The following is a description of a gene set: Any process that activates or increases the frequency, rate or extent of the process involved in the formation, arrangement of constituent parts, or disassembly of cell projections. species: Homo sapiens Human Gene Set: GOBP_POSITIVE_REGULATION_OF_CELL_PROJECTION_ORGANIZATION, and this is the list of marker genes: IL1RAPL1, SCN1B, ZMYND10, CORO1B, EHD1, LYN, CRABP2, WASHC5, DVL1, WNT3A, CYFIP1, DLG4, PLEKHM1, RAB11FIP3, DISC1 (NCBI Gene Id 80138), RP1, WRAP73, PROM2, KCTD17, PLCE1 (phospholipase C epsilon 1), PUM2 (NCBI Gene Id 23369), TNFRSF12A, DZIP1, BMP5, CDC42EP2, TUBB2B (tubulin beta 2B class IIb), MIR221, AGRN, TWF1, PTK7, CEP135, WNT3, WNT5A, MIR222, MACF1, NLGN1, TIAM2, ABL2 (NCBI Gene Id 27), RAPGEF2, PACSIN1, MSTN, RND2, CDC42EP3, PARP6, AVIL, PTN, GPM6A, FES, SERPINI1, FNBP1L, TGFBR1, MEGF8, ATP1B2, HAP1, LRP8, SMAD1, CARMIL1, ENC1, STMN2, TMEM30A, ARF6, MNS1, AKIRIN1, FAM98A, KIDINS220, TENM1 (teneurin transmembrane protein 1), PLA2G3, TENM3, FBXO38, RREB1, NRP1, TOX, ABI2, SEMA5A, DHX36, TRPV2, ANKRD1, C15orf62, MAP2K1, MIR133B, SS18L1, ALK, PPP1R35, NEGR1, STK25, DMD, GPC2, PLXNB3, ITGA3, GRN, FRMD7, HTT, DBN1, MIR200C, RAB21, PLK5, HSP90AA1, APOE, PIK3CA (NCBI Gene Id 5290), BRK1, SERPINF1, EPS8L3, PPP2R5B, SEMA7A, ADNP, MAPT, ITGA2 (NCBI Gene Id 3673), EPS8L1, ATP8A2, RAB8B, AMIGO1, GSK3B, BCL11A, ARAP1, NEDD9, SMURF1, WASL, VLDLR, ATMIN, FSCN1, CUX2, STAU2, SCARF1, ACTR3, ARHGAP35, SKIL, DAB2IP, ZFYVE27, TAPT1, CAMK2B, RGS2, EPHB2, PRKD1, CCL19, TIAM1, CCR7, BBS4, ZDHHC15, CCL21, STYXL1, CAMK1, ROBO1, SRF, GPRASP3, CFL1, LTK, CAMK1D (NCBI Gene Id 57118), NEFL, EPS8, MTOR, CDC42, HDAC6, TNN, FMR1, MAP6, DVL2, KATNB1, RAC1, FYN, RAPGEF1, ROBO2, TBC1D24, FGFR1, RYK, NGF, ANLN, SEPTIN9, VIL1, MIR431, FEZ1, LCN2, INS, SEPTIN7, TENM2, TWF2, ZNF804A, CDKL3, NCKIPSD, WNT1, RELN, CFLAR, TRPC5, MDK, P2RY12, RET, NFE2L2, CXCL12, RALA, AP2A1, NTRK3, SLITRK1, FUZ, LPAR3, MIR21, CCDC88A, TGFB3, MAP3K13, ALKAL1, PIK3R1, MAP2K2, MIEN1, ENTR1, EZH2, MAP1B (microtubule associated protein 1B), RHOQ, DDR2, ENPP2, GOLGA4, NDNF, KAT2A, RIPOR2 (NCBI Gene Id 9750), SHOC2, CDKL5, NTN1 (netrin 1), ABL1, ZMYND8, NTRK2, APC, LIMK1, ISLR2, NCKAP1, SEMA4D, APBB1, S100A9, NDEL1, CNTN1, CORO1C, ARMCX5-GPRASP2, FN1, PTK2B, CNTF, EP300, BMP7, PTK6, BMPR2, SLIT2, PLXNB2, NTRK1, L1CAM, PTPRD, PAFAH1B1, PLPPR5, F2RL1, ARHGEF7 (NCBI Gene Id 8874), SHOX2, WASF2, NRDC, EPO, MYO3A, BMPR1A, ATOH7, NEURL1, CHODL, CUX1, SAXO1, DDR1 (discoidin domain receptor tyrosine kinase 1), NUMBL, CDC42EP1, ARPC2, FBXW8, DSCAM, EEF2K, SETX, PLXNB1, METRN, CLRN1, HRAS, TMEM106B, ALKAL2, CDH4, EPHA3, ROBO3, RETREG3, FIG4, WASHC1, CAPRIN2, CCP110, PLEK2, KDM1A, P2RX7, SF3A2, ANKRD27, NDRG4, ZEB2, MYO3B, CBFA2T2, CROCC, MARK2, STK11, ARSB, AUTS2, ANAPC2, RUFY3, CUL7, CX3CL1, PFN1, POU4F2 (POU class 4 homeobox 2), CEP120, EPHA4, BDNF, CAPRIN1, SHTN1, ITPKA, NIN, EFNA5, PRKCI, SNX3, GDI1, IST1, RGMA (NCBI Gene Id 56963), ADCY10, RAP1A, TTBK2 (NCBI Gene Id 26044), ATF1, NPTN, MARK4, SLC30A1, KHDC3L, VEGFA, TRAK1, SRC, BRAF, FZD1, SCARB2, OBSL1, FUT9, KAT2B, IFT88, DVL3, TRIM67, OCLN, DDX56, PLXND1, IFT20, BAIAP2, PLXNC1, CDC42EP4, KIT, CARMIL2, MAGI2, GRIP1, DOCK11, PALM (NCBI Gene Id 5064), NCK1, FZD4, RIT2, DEF8, RAC2, COBL, ITGA6, P3H1, DPYSL3, ACTR2, CDC42EP5, EPS8L2, LRRC7, PAK1, CENPJ